The following is a description of a gene set: Genes predicted to be targets of miRBase v22 microRNA hsa-miR-500b-3p in miRDB v6.0 with MirTarget v4 prediction scores > 80 (high confidence targets). species: Homo sapiens from publication Chen Y, Wang X (PMID 31504780) Human Gene Set: MIR500B_3P, and this is the list of marker genes: SLC25A13, SNX16, TEDDM1, TCERG1, GPR26, HDAC9, LYRM2, CBX8, DHX33, TCEANC2, NEURL1B, OTX2, CCNP, HES2, DPT, OR13A1, EPHA8, HPCAL4, SAMD8, LCOR, LEPROT, CNTD1, HSD17B7, SLC4A8, IRGQ, PKNOX2, CALU, MAVS, BAALC, ACTR3C, COA7, CCDC178, FSTL3, CDYL2, FSCN1, DHTKD1, BTN2A2, SFMBT1, ARHGEF15, CD83, TTPAL, SAE1, RREB1, CAST, KIAA1549L (KIAA1549 like), PLEKHA8, PATE1, PDZRN3, NR4A3, GSTM3, TMEM144, RBM33, ARHGAP18, DDHD1, SERF1B, SFRP5, LYSMD4, PRSS8, TCEAL4, CREBRF, POLDIP3, TICAM1, EP300, FAM171B, ST3GAL1, TLE1, YTHDF3, USP13, PRKAG1, KDM4C, RALA, BLZF1, SH3PXD2A, CDYL, THRB, USP16, ABCA12, MFSD11, DEF8, LHFPL1